The following is a description of a gene set: Human Gene Set: HP_SINUS_BRADYCARDIA Bradycardia related to a mean resting sinus rate of less than 50 beats per minute. studied in species Homo sapiens Sinus bradycardia, and this is the list of marker genes: HEPHL1, TRDN, BVES, CALM2, TBX5, CAV3, KCNQ1, GNB2, KCNJ5, SNTA1, KCNE1, SCN4B, GFM2, CALM3, TNNI3K, PRKAG2, KCNA5, KCNH2, MYO1H, KCNE2, AKAP9, TNNT2, ANK2, NOS1AP, CALM1, HCN4, LMNA, CACNA1C, SCN10A, SCN5A (sodium voltage-gated channel alpha subunit 5)